Given this list of marker genes RPS27 (NCBI Gene Id 6232), RPL35A (NCBI Gene Id 6165), MEF2C, RRAS2, GSTA4, CD22, LRRC37A3, ZEB1, DUSP1, LARGE1, CD40LG, RPS15A, GABBR1, RIC3, SCD5, RAB11FIP3, ACSL6, CXCR4, NIPSNAP3B, PRKY, SNX29, ANKRD34C, PRKD2, SAP30L-AS1, OGG1, RPS27A, IL24, IL15, SPINK2, PIM2, ELOA-AS1 (NCBI Gene Id 100509187), GTPBP3, RPS7, RPS11, MCM2, PIK3C2B, RPS17, DND1, CD72, HAUS5, TCL1A, POU6F1, MCTP2, WRAP53, GVINP1, RPL21, PARP16, DDR1, LRIG2, ARHGAP5, SZT2, MINDY2, CR2, CLUHP3 (clustered mitochondria homolog pseudogene 3), KLHL35, PMS2P1, MARCHF3, LRBA, PHC1, SLC35F2, PTPRCAP, TAF4B, RPL28, OTUD3, TSPYL2, CYFIP2, SIDT1, NR3C2, SLC16A7, HOPX, A4GNT, FZD10, DEFA5, RETREG1, FAM53B, RPL34, CEP43, ZNF571, GPRASP1, SMAD3, CNR2, MS4A1, IDI2-AS1, RADX, RPS23, PEG10, CORO2B, USP9Y, TSC22D3, RPL32, IFNA17, ZNF821, UTP25, GSTA1, ZNF154, CNR1, GALNT3, PAK6, FBXO4, SBNO1, FCMR, NRF1, METTL18 (NCBI Gene Id 92342), ZFTA, MID1, SPRY4, DPH5, CLCN4, WDR48, SELL, SLC35E2A, PVRIG, VAV3, SPIB, RPL13A, LBH, UTY, TIAM2, PRIM1, GPR18, RPL22, ENSG00000274253, KLF2, TBC1D19, P2RX5, POU2AF1, TESK2, HNRNPA3P1, HLA-DOA, LDOC1 (NCBI Gene Id 93489), PMEL, PHLPP2, GPM6A, SERPINB9, FZD6, MTMR10, CDC7, GARRE1, R3HDM4, IGKC, FRAS1, MIR600HG, DLG5, ISG20, TGIF2, RPL27A, CD28, NOP53, SLC6A16, SEMA4F, PATZ1, EHD3, CD24, CD38, TENT5C, NCR3 (natural cytotoxicity triggering receptor 3), TSHB, TAF9B, SKAP1, PIP5K1B, EPHA4, SMPX, BTG1, ZNF532, ITM2C, RIPOR2, TMEM156, PDLIM1, ENDOD1, IGLV1-44, MEST, BCL11A, CD37, FMO5, SLC25A37, CD200 (NCBI Gene Id 4345), DCAF17, IRS1, CASZ1, DMC1, TRMT2B, NCOA2, FAM30A, BACH2, HLA-DOB, LTB, DYM, CD19, MVK, RPL37A, PCDHGA10, POLR1HASP, BCL7A (BAF chromatin remodeling complex subunit BCL7A), KLK2, STAP1, FBXO42, BACE2, CNKSR2, here is a description of the gene set: from publication Abbas AR, Baldwin D, Ma Y, Ouyang W, Gurney A, Martin F, Fong S, van Lookeren Campagne M, Godowski P, Williams PM, Chan AC, Clark HF (PMID 15789058) Human Gene Set: GSE22886_NAIVE_BCELL_VS_DC_UP studied in species Homo sapiens Genes up-regulated in comparison of naive B cells versus unstimulated dendritic cells (DC). Immune cell-specific expression is one indication of the importance of a gene's role in the immune response. In order to identify such patterns, we set out to broadly profile gene expression in a variety of immune cells.